The following is a description of a gene set: species: Homo sapiens Human Gene Set: MIR613 Genes predicted to be targets of miRBase v22 microRNA hsa-miR-613 in miRDB v6.0 with MirTarget v4 prediction scores > 80 (high confidence targets). from publication Chen Y, Wang X (PMID 31504780), and this is the list of marker genes: UHMK1 (NCBI Gene Id 127933), MPP7, STARD7, DDX5, PDCD10, MEA1, AP1B1, CD2AP, TSPAN4, THRB, CDKL5, KLF4, UST (uronyl 2-sulfotransferase), ATF2, RNF145, ELF1, CHSY1, SNX2, DRD1, SEMA6D, NEDD9, SEC22B, NAB1, MMRN1, SLC25A30 (NCBI Gene Id 253512), THAP12, S100A7A, WDR48, SLC37A3, TBC1D15 (TBC1 domain family member 15), ASXL3, MYOCD, HELZ2, PDIK1L, TAF1B, AP1G1 (adaptor related protein complex 1 subunit gamma 1), TFE3, PPP4R2, SLC10A7, CAAP1, SLC39A10, GPR158, PARP11, ASH2L, GNPDA2, THBS1, WIPF2, LASP1, PBX1 (NCBI Gene Id 5087, PBX homeobox 1), ARHGAP20, CCSAP, UBE4A, FAM72D, FN1, KIF2A, CLCN3, LRCH1, CTTNBP2NL, WNK3, ETS1, PHAX, G6PD, FAM91A1, SRGAP2, ADAM12, ZMAT3, FOSB, ANKRD29, CLTC, SLC6A11, HACD3, BTAF1, PAX3, MAP4K2, GCLC, GPD2, SAMSN1, OSBPL7, VAMP4, SRSF1, SH3TC2, CCDC146, METTL21A, MEOX2, FRS2, SPRN, TPPP, CNN3, BACH2, BSCL2, GLCCI1, HSP90B1, SPRED1, DLG1, RNF138, KANK4, TBX3, SEC23B, SLC25A53, NET1, SATB1, BPNT1, PLPPR4, USP33, GCH1, HMGN1, PLXNA4, UNC119B, MTX1, PDCD4, TRIM2, KAT6B, PALS1 (protein associated with LIN7 1, MAGUK p55 family member, NCBI Gene Id 64398), SCAF11, PGM2, TIMP3, RAB5A, CORO1C, MAB21L1, KMT5B, MIPOL1, HNRNPU (NCBI Gene Id 3192), CITED2, MYLK, CPEB1 (NCBI Gene Id 64506), SULF1, TMEM243, TBCK, SRI, RIT2, NFAT5, RNF38, MMD, SOWAHC, PREX1, TNPO2, ZFP36L1, PPIB, HIGD1A, GLCE, HSPD1, ATP6V1A, SMIM14 (NCBI Gene Id 201895), ZNF24, FOXP1, ZFP36L2, MXD1, EBPL, MAL2, AJUBA, ADAR, CAP1, SNAI2, WBP1L, KAT6A, STMN2, STAG2, SOX9, NCL, PHIP, MAP4K3, ZEB2, IFT52, FAIM, ARF3, EIF1AX, SLC35G1, FNDC3A, PHF6, TBX18, EDN1, SYT1, TRA2B, SERP1, FBXL14, HMBOX1, JOSD1, CCL2, CERS2, LAMP2, CREM, LRRC8A, STC2, RARB, XPO6, BDNF, CREB5, PIK3C2A, UTRN, TMSB4X, YWHAZ, FAM72C, SLC35B3, POGK, SAMD8, MBLAC2, TWF1, RGS7 (NCBI Gene Id 6000, regulator of G protein signaling 7), ADGRA3, MGAT4A, NETO2 (neuropilin and tolloid like 2), NCOA1, WWC1, NBEA, ZNF280D, MEX3C, API5, SLC29A3, PTPN1, KCNIP3, SLC39A9, SLC25A36, GRK6 (G protein-coupled receptor kinase 6), WDR1, GPR137C, IP6K2, CAVIN2, MFSD14A, DGKH, ADPGK, HYCC1, FBXW7, INSM1, AP1S1, HIVEP3, SMARCC1 (NCBI Gene Id 6599), MMD2, SS18, PCDHB13, HS3ST3B1, FAM72B, MATR3, PRKCE, FAM72A, SLC25A22, NINJ1, PAX7, SEC61A1, RIMOC1, MON2, ZBTB41, AZIN1, SLC44A1, CREBL2, CPED1, ANXA2, MCHR1, ZNF800, NRP1, CCDC32, CLOCK, HP1BP3, TMEM178A, TOX3, RFLNB, SKIC8, SLC38A3, BCL11A, PTPRG, PEAK1, KCTD10, MAX, ZNF547, EPHB1, NFATC3, TNKS2, CDK14, EIF4E, CEBPZ, DDX55, C2orf69, FLI1, NDRG3, FUBP1, NOL4L, PTPN14, ARCN1, NFATC2, IGF1, AKAP11, ATG13, MET, SRSF9, TTC7B, NXT2, RABGAP1L, FNDC3B, TMCC1, ACTB, HACE1, PICALM (phosphatidylinositol binding clathrin assembly protein), KMT2E (lysine methyltransferase 2E (inactive)), IMPACT, GJA1, TAGLN2, SLC7A2, RTN4IP1, FAM168A, CBL, EEIG1, CAPRIN1, NEXMIF, PDE7A, MECOM, NUP50, YWHAQ, ZNF281, KTN1, ZBTB6, TRAPPC3, IPO8, RFWD3, FBXO33, NALF1, SMARCB1, PIRT, RICTOR, HIPK3, PABPC1L2B, BHLHE22, MINDY2